The following is a description of a gene set: Human Gene Set: GOMF_HEXOKINASE_ACTIVITY species: Homo sapiens Catalysis of the reaction: ATP + D-hexose = ADP + D-hexose 6-phosphate., and this is the list of marker genes: HK2, HK3, GCK, HK1 (hexokinase 1), HKDC1